The following is a description of a gene set: Temporal analysis of B cell activation in vitro using CD40L and IL-2/4/5 cytokines in wild type Irf4+/+ B cells or in mutant Irf4-/- B cells harboring a tet-inducible allele of Irf4. IRF4 expression was restored, or not, in the Irf4-/- background by culturing in the presence of low or high concentrations of doxycycline. The results provide insight in the role of IRF4 expression levels in coordinating different programs of B cell differentiation. Human Gene Set: GSE46606_UNSTIM_VS_CD40L_IL2_IL5_3DAY_STIMULATED_IRF4HIGH_SORTED_BCELL_UP studied in species Homo sapiens Genes up-regulated in at day 0 B cell IRF4-KO versus CD40L and IL-2 IL-4 IL-5 stimulated at day 3 B cell IRF4high. from publication Ochiai K, Maienschein-Cline M, Simonetti G, Chen J, Rosenthal R, Brink R, Chong AS, Klein U, Dinner AR, Singh H, Sciammas R (PMID 23684984), and this is the list of marker genes: CNTN3, TMPRSS15, HSPE1, AGPAT1, FAM149B1, NUDCD1, ALDH8A1, HAUS3, MED20, TTC9B, DENND1C, NOXO1, MIIP, ATG3, PDCD6IP, INTS3, CLDN12, DNAJC3, TGM2, ERCC5, GFM1, CSNK1G2, ZDHHC3, DRG2, MYNN, ZNFX1, PPP2R5A, ARMC2, LETM1, CLASRP, CARD10, CREB3L2, PIGH, RAI14, DDR1, UVSSA, NAGPA, GINM1, INTS11, ARRB2, USP22 (ubiquitin specific peptidase 22), APBB1, CDC42BPB, ZBTB3, BNIP1, ACOT11, AP3S2, KCTD3, POR, TMEM120B, TMEM109, RCC1L, RPS6KB2, DRAM2, POC5, ZBTB43, NDUFA6, PIGO, SLC5A10, DERL2, TCEA1, GPAT4 (glycerol-3-phosphate acyltransferase 4), PRRX1, LRRC46, CNOT10, VWA2, PIGN, VCPIP1, XPO6, IARS2, UCP3, ZBTB9, SCRIB, HOXA9, IDI1, SLC35F5, MMP10, RBM42, ROM1, PGGHG, POLR1F, FKBP8 (FKBP prolyl isomerase 8), ADCY3, ZFHX3, SLC7A6OS, CEP76, NTAN1, AP2A2, SRPRA, GKN2, ZDHHC5, LMNB2, LAG3, MTERF4, WDR20, RBM28, SLC25A17, ASAP2, LYPLA2, FLII, ADH5, CD27, RPE, MRPS26, GBF1, CPT2, UROS, JHY, RFX4, RCOR1, LIPF, RPRM, EML3, RXRB, LY6G6D, TTC38, KDELR1, DCTN1, TRIT1, APOBEC2, CTU2, CHPF2, ADCK2 (aarF domain containing kinase 2), C19orf47, ACYP2, TMEM219 (NCBI Gene Id 124446), FAM98C, RMDN3, NBEAL2 (neurobeachin like 2), SLX9, ZNF281, PPARA, FIRRM, SCN7A, ACBD6, SLC35A2, ZBED5, CLEC4G, CLN6, DDX24, LURAP1, KDELR3, DTX3L, GUCA2B, TCOF1, RNPS1, MSX1, ABHD8, NT5C2, DCP2, ZDHHC7, SH3D19, SLC10A3, HNRNPL, ARHGEF3, HMGB1, ABLIM3, PADI1, CFAP206, VPS72, SMC5, NSRP1, ZDHHC15, MCCC2, GCNT1, RELB, FBXL6, FBRSL1, AATF, FAM234A, MXI1, PTCD2, EBF1 (NCBI Gene Id 1879), PEA15, MGAT5B, KATNB1, STX17, HSPA13, ZMYND11, DOCK3, TOP3B, MERTK, HMGA1, SERPINC1, PLEKHA7, GRM3, SYCE3, DIS3L, ZKSCAN5, ZNF8, CCK, ZFP69, WASHC5, ATMIN, GRM7, MIOS, INS, MCAT, FAAP100, ANXA11